Given this list of marker genes Hbb-bh2, Prdx3, Mpo, Hbq1b, Epx, Prdx6b, Prdx1, Prdx5, Gpx3 (glutathione peroxidase 3), Gpx1, Prdx2, Hba-x, Txnrd1, Hbb-bs, Nnt, Snca, Hbb-bh1, Hbb-bt, Mt3, Apoa4, Prdx4, Hba-a1, Pxdn, Cat, Tpo, Hbb-bh0 (hemoglobin, beta, pseudogene bh0), Hbb-y, Prdx6, Hbq1a, here is a description of the gene set: The chemical reactions and pathways resulting in the breakdown of hydrogen peroxide (H2O2). studied in species Mus musculus Mouse Gene Set: GOBP_HYDROGEN_PEROXIDE_CATABOLIC_PROCESS